Given this list of marker genes EIF4E, COX7B, MFAP1, LSM3, RFC4, PCLAF, INSIG1, PNPLA6, PARP2, DLG1, RSRC2 (NCBI Gene Id 65117), TTF2, GNPAT, MID1, CCL5, ARRB2, PEX1, CARD8, FANCG, SMC1A, ALCAM, SS18, MBNL1, FKBP15, CHD1, RRM2 (NCBI Gene Id 6241), here is a description of the gene set: Human Gene Set: CHOW_RASSF1_TARGETS_UP Genes up-regulated in C666-1 cells (nasopharyngeal carcinoma) by stable expression of RASSF1. species: Homo sapiens RASSF1A is a tumor suppressor gene on 3p21.3 frequently inactivated by promoter hypermethylation in nasopharyngeal carcinoma (NPC). To identify RASSF1A target genes in NPC, we have investigated the expression profile of the stable RASSF1A transfectants and controls by high-density oligonucleotide array. A total of genes showed differential expression in the RASSF1A-expressing cells. These RASSF1A target genes were involved in multiple cellular regulatory processes such as transcription, signal transduction, cell adhesion and RNA processing. The RASSF1A-modulated expression of eight selected genes with the highest fold changes (ATF5, TCRB, RGS1, activin betaE, HNRPH1, HNRPD, Id2 and CKS2) by RASSF1A was confirmed in both stable and transient transfectants. Compared with the RASSF1A transfectants, an inverse expression pattern of activin betaE, Id2 and ATF5 was shown in the immortalized nasopharyngeal epithelial cells treated with siRNA against RASSF1A. The findings imply that the expression of activin betaE, Id2 and ATF5 was tightly regulated by RASSF1A and may associate with its tumor suppressor function. Strikingly, overexpression of Id2 is common in NPC and RASSF1A-induced repression of Id2 was mediated by the overexpression of activin betaE. The results suggest a novel RASSF1A pathway in which both activin betaE and Id2 are involved. from publication Chow LS, Lam CW, Chan SY, Tsao SW, To KF, Tong SF, Hung WK, Dammann R, Huang DP, Lo KW (PMID 16116475)